The following is a description of a gene set: Human Gene Set: KRISHNAN_FURIN_TARGETS_UP species: Mus musculus Genes up-regulated in naive T lymphocytes lacking FURIN: Cre-Lox knockout of FURIN in CD4+ cells. from publication Krishnan MN, Ng A, Sukumaran B, Gilfoy FD, Uchil PD, Sultana H, Brass AL, Adametz R, Tsui M, Qian F, Montgomery RR, Lev S, Mason PW, Koski RA, Elledge SJ, Xavier RJ, Agaisse H, Fikrig E (PMID 18690214) West Nile virus (WNV), and related flaviviruses such as tick-borne encephalitis, Japanese encephalitis, yellow fever and dengue viruses, constitute a significant global human health problem. However, our understanding of the molecular interaction of such flaviviruses with mammalian host cells is limited. WNV encodes only 10 proteins, implying that it may use many cellular proteins for infection. WNV enters the cytoplasm through pH-dependent endocytosis, undergoes cycles of translation and replication, assembles progeny virions in association with endoplasmic reticulum, and exits along the secretory pathway. RNA interference (RNAi) presents a powerful forward genetics approach to dissect virus-host cell interactions. Here we report the identification of 305 host proteins that affect WNV infection, using a human-genome-wide RNAi screen. Functional clustering of the genes revealed a complex dependence of this virus on host cell physiology, requiring a wide variety of molecules and cellular pathways for successful infection. We further demonstrate a requirement for the ubiquitin ligase CBLL1 in WNV internalization, a post-entry role for the endoplasmic-reticulum-associated degradation pathway in viral infection, and the monocarboxylic acid transporter MCT4 as a viral replication resistance factor. By extending this study to dengue virus, we show that flaviviruses have both overlapping and unique interaction strategies with host cells. This study provides a comprehensive molecular portrait of WNV-human cell interactions that forms a model for understanding single plus-stranded RNA virus infection, and reveals potential antiviral targets., and this is the list of marker genes: JUN, HSPA1A (NCBI Gene Id 3303), HSPA8, H3-3B, DTL, TGM2, FOS, S100A4, MGARP, IGHG1